The following is a description of a gene set: This event has been computationally inferred from an event that has been demonstrated in another species.<p>The inference is based on the homology mapping from PANTHER. Briefly, reactions for which all involved PhysicalEntities (in input, output and catalyst) have a mapped orthologue/paralogue (for complexes at least 75% of components must have a mapping) are inferred to the other species. Reactome Pathway: Zinc transporters part of: Metal ion SLC transporters electronically inferred by orthology from the curated human pathway studied in species Mus musculus, and this is the list of marker genes: Slc39a4, Slc30a5, Slc39a2, Slc39a6, Slc30a8, Slc39a14, Slc39a7